The following is a description of a gene set: Centriole assembly in which a centriole arises de novo, rather than by replication from an existing centriole. This process may occur via different mechanisms. Examples include the deuterosome pathway in multicilated epithelial animal cells and formation of centrioles during parthenogenesis in some insects. species: Homo sapiens Human Gene Set: GOBP_DE_NOVO_CENTRIOLE_ASSEMBLY, and this is the list of marker genes: CEP152, CDC20B, DEUP1, CCDC78, CEP63, PLK4